Given this list of marker genes TRIP13, FCGR3A, ACTL6B, GMFG, NFE2L2, RAB15 (NCBI Gene Id 376267), NCF2, NRBP2, DLG3, GAS8, MED11, BCL2A1, HTRA1, NINJ1, PRICKLE1, PSD, TBC1D16, STX4, NIPAL3, TGFBR2, CD34, ASAH1, MYO1F (NCBI Gene Id 4542), FKBP1B, NEURL2, SNX5, TGFB3, C1orf54, BTG3, ARHGAP18, CFAP96 (cilia and flagella associated protein 96), C8G, ST6GALNAC4, EFEMP2, USP43, SLC39A12, BMPER, TUBA1A, PSAP, MTMR11, HTRA2, DENND1C (DENN domain containing 1C), VAT1, OAS1, GPR179, CYP2E1, SPHK1, TULP3, ZNF503, SYK, CCL2, AAK1, SPIN2A, SLC22A7, RHOH, LYL1, ARPC2, LAYN (NCBI Gene Id 143903), APOBEC3B, PLIN4, LAMA2, FOXP1, MMP3, GASK1B, EPB41L2, ANKRD33B, GNE, SNX27, IFIT2, SCNN1A, OTULINL, PTPRO, GSTM5, RGS19, CD200R1, KLKB1, EVA1A, MCM3, CAPN2, GATA6, SLC7A8, PLCD3, PRKCD, CTTNBP2NL, SLPI (secretory leukocyte peptidase inhibitor), GNB1, CD22, NOL4L, CDC42, C3AR1, SMOC2, HCST, TMEM229B, AGPAT4, C19orf38, RAB8B, TRPC4, IGSF8, CYGB, COMTD1, LRP12, PTGR2, DNA2, INIP, RGS18, PCDHB16, TRIL, GPNMB, TMEM273, KYAT1, CENPA, FABP7, CD180, LCE3B, SLC27A3, STK10, PLAUR (plasminogen activator, urokinase receptor), FES, PPM1L, CD86, SURF1, SLC41A2, SKP2, NPL, LRCOL1, SPTLC2, EMP3, SLFN12, WFS1, RCN1, PRAF2, SLC39A6, PDE3B (phosphodiesterase 3B), ANXA3, SDCBP2, HEATR1, CLN8, FBXO25, CNR2, ST8SIA4, CBFB, SRD5A3, LGR4, TONSL, AVPR1A, STAT4, ABCG1, HAVCR2, TRIM5, LTBP1, F2RL1, MYO9B, NUMBL, BIRC5, FHL1, IKBKE, SMIM5, MYO5A, APOBEC1, SYNGR1, CA2, TMEM164, PLXDC2, OLIG2, ARMC7, SNN, TMPRSS3, GALNT3, COMMD10, TEN1, MDFI, NLGN2, PIK3IP1, ELF3, HYCC1, CDKN2C, DCDC2C, TAX1BP3, LIPC, WFDC3, DOK2, TREM2, PMAIP1, PAWR, MRC1, SDC2, MYOF, PGM1, MANBA, SESTD1, UBD, PRKX, CHST14, KRT18, PTPRC, ITPR3, SLCO2A1, GDF10, TMEM43, AUTS2, MCL1, LRRC27, TTC39C, FEN1, SMS, RFTN2, SLAMF9, CAMKK1, GSS, CREG1, ADCY7, SERPINA11, EHD2, HILPDA, ESPL1, MAP3K8, ARPC1B, RUBCNL, SRGN, FRMD4A, RAP2B, TLR4, MYZAP, FKBP1A, MACIR, EHD4, HLA-DQA2, L1CAM, FSHR, MXRA8, CADPS2, CSF1R, TMEM144, BCL2L13 (NCBI Gene Id 25779), SDF2L1, RPIA, PLTP, PPIC, TREH, SYP, TUBB4A, AK8 (adenylate kinase 8), PTGER2, DDX31, MAP3K20, ATP6V1B2, CYRIB, OR4D6, ATP6V1A, SPACA9, CASP1, DDAH2, FUCA2, SLK, ME2, MELTF, LPL, RIPK3, TREX1, TIFAB, CDK15, RPS6KC1, FAM111A, PCGF3, GNS, GPATCH2, CYTIP, TANC1, PIMREG, B4GALT2, FAM83F, FGD6, OBSL1, LMNA, AFAP1L2, HOXB2, CASP2, HK2, PSRC1, SNX24, ZRANB3, LGMN (legumain), C3orf52, PKMYT1, PTK2B, TWF2, CDCP2, DCXR, PLA2G4A, GNMT, MRE11, MT3, CDK18, DRAM1, GSN, ACTG1, TPD52 (NCBI Gene Id 7163), CERS6, UNC93B1, LHFPL6, TNFAIP6, TFEC, SLC9A9, MAGIX, ATP13A2, CCDC120, GPR65, TGFB1I1, COL1A1, MAN2B1, ITM2C (integral membrane protein 2C), GPR137, PLA2G7, CADM1, NOSTRIN, CSF2RB, GALNS, GGT5, HPGDS, RAB34, CPNE9, DGCR2, PRMT2, ASGR1, TRAM1L1, CCL15, TOR4A, ZFYVE26, DOCK11, VIPAS39, DBH, LACC1, FRZB, LPXN, PBLD (NCBI Gene Id 64081), RNH1, HEPH, APH1B, PLXNB2, ARAP1 (ArfGAP with RhoGAP domain, ankyrin repeat and PH domain 1), OR56B4, NLRC4, RNF122, PCNA, ERMP1, MTHFD2L, NRG1, TPH2, SMPDL3A, ATP6AP2, APOL1, DNMT1, ZDHHC6, PALB2, CD84, PPIB, CD5L, PCOLCE, TXNRD1, SLC11A2, PIF1, PLEK, ICA1, EBI3, SAT1, POLD4, RBMS3, PRUNE1, KLHL6, INPP5D, FMN1, BIN3, P2RY10BP, IL11RA, DCK, ARHGAP25, NDRG2, HSD3B1, SEMA3G, NIBAN1, FBN1, C8B, ADCY6, GPSM3, MTHFD1, RNF217, FERMT3, NRP2, EML1, SLC43A1, PSMD8, SPRED2, C5, PIP5KL1, UCK2, ABCC5, CAPNS2, CPXM1, SPARC, SRXN1, MICAL2, UBTD1, ALDH1B1, IL33, MPEG1, P3H2, ANXA4, PLK2, OPN3, SLCO3A1, CD68, ZBTB48, PDLIM4, PIK3AP1, ANPEP, RASSF8, CTSH, UNC5B, PIP4P2, PDGFRB, CLEC10A, CCNA2, CAPG, PTPN1, TNIP1, TMSB4X, SYNPO (NCBI Gene Id 11346), LRIG1, KCNK13 (NCBI Gene Id 56659), TNC, IFI30 (IFI30 lysosomal thiol reductase), AK1 (NCBI Gene Id 203), ARL11, SLC4A7, TTC28 (tetratricopeptide repeat domain 28), GLIPR1, TAOK3, RAC2, ARHGAP10, HAL, ASL, SLAMF7, RHOJ, TCEAL5, RAB2A, CLIC1, SMOX, KCTD17, KCNN4, F10, SCN11A, FRAT1, AKR1B10, SNX1, RTL6, FAM131A, SCD, STXBP2, GJB1, CDS1, PRR13, DENND4B, PRR5L, SLC4A3, MFAP2, MSR1 (macrophage scavenger receptor 1), TYROBP, YWHAH, EPSTI1, TBC1D1 (TBC1 domain family member 1), PDGFRL, FLT3, TEC, TNFRSF18, MCMBP, PARP8, OASL2P, MSANTD3, CCDC102A, TAGLN2, HEXB, GADD45B, PRODH, STK24, PLXNC1, COL5A2 (NCBI Gene Id 1290), C1QB, HTRA3, ABCC4, IER5, MICU2, RPS6KA2, GLB1, PANX1, BACH1, TLE4, CLEC1B, PLXNB3, NECAB1, THEMIS2, OACYLP, TMEM86A, SCCPDH, UPB1, CYP4F2, SGPL1, FKBP10 (FKBP prolyl isomerase 10), C3orf80, PICALM, CLEC7A, NAIP, CD36, MAP3K15, UNC13D, IFIT3, BTC, RIN2, FBXO32, RIPPLY3, ANAPC13, HAUS8, PRODH2, ARRB2, CLDN22, FSCN1, P2RY14, CNDP2, OLFML3, ANTXR1, IL18BP, TNFAIP8, HACD4, ARHGDIB, VSIR, CACNB3, SLAMF6, MTRFR, OR51M1, IRF5, TBC1D9, CARD19, BST1, AIF1, PXMP2, GBA1, SCLY, NFAM1, ALDH3B1, VOPP1, CD63, FOS, F11 (NCBI Gene Id 72031), ENAH, CYP2C8, DROSHA, IL10RB (NCBI Gene Id 3588), TXNDC15, CIDEA, RAB11FIP5, FMOD, MAPK7, UBTD2, CARD11, ABCA5, TLR2, VIM, LDHB, GNB3, TOM1, DUSP10, TRIM32, SULF1 (NCBI Gene Id 23213), SERPINB9, LONRF3, CIDEC, SPMIP3, FOXS1, PRRX2, RGS14, SMC1B, ACY1, ZFP90, TK1 (NCBI Gene Id 7083), CD276, RIPOR3, AGMAT, PLEKHO1 (NCBI Gene Id 51177), STXBP5, ABR, OSTF1, SYBU, PYHIN1, GMNN, RAN, CHST12, COL14A1, MTHFS, STAB1, AKNA, CASP12, THBS2, DSE, EPB41, FRMD6, VAMP4 (vesicle associated membrane protein 4), LAT2, SPDL1, CYTH4 (cytohesin 4), FCGR2A, BICC1, DNAJB11, ACVRL1, IGSF6, PYCARD, CMAS, TPST1, ART4, GAL3ST1, LIPA, STEAP1, DOCK10, HK3, ADAMTS3, CDCA3, SERPINB6, RIPOR1, BLVRB, COLGALT1 (collagen beta(1-O)galactosyltransferase 1), SUSD4, GIPC2, CD44, CD14 (CD14 molecule), RNF207, CD38, B4GALT7, SORT1, NIBAN2 (niban apoptosis regulator 2), RGS10, JUN, AHCY, HMOX2, SLC31A1, COL16A1 (collagen type XVI alpha 1 chain), ARMC3, BLVRA, CFP, OBI1, GPX7 (NCBI Gene Id 91407), LAPTM5, RASSF5, PLGRKT, PEDS1, FCER1G, HMGA1, PPP1R14B, RHOV, SRPX, SH3BP2, EMILIN1, WSB2, CHTF18, PTCHD1, TNFSF13B, AIRN, DYSF, CSF3R, MPND, MZT2B, SAMSN1, ATP6V0A1, RASGEF1A, SLC5A4, MPV17L, ACE, MOCOS, ATAD2, SPATS2L, C1QC, SLC48A1, LOXL1, PILRA, CTC1, NLRC3, EAF1, LASP1, SLC6A6, PEA15, GPX8, LOXL2, IL1RL1, SPRR1A, WDR91, ATP1A3, DOCK2, CLCNKA, FBLN2, ATF3, ARPC5, HVCN1, SLC4A11, ACSS1, BGN, SYNGR2, VCAM1, RAB19, SH3BGRL3, SCPEP1, CERCAM, DNMT3A, FRRS1, CSTB, TSPAN33, CERS5 (NCBI Gene Id 91012), LGALS3BP, DPP7, CDC7, MMP13 (NCBI Gene Id 4322), SPATA6, KCTD10, PIP4K2A, KRTAP19-8, RASSF1, ECI2, COL1A2, BATF2, MSC, IGFBP2, PTPRE, LAIR1, HAGH, PTPN22, MMP2, SOAT1, CHSY1, NRROS, ALDH18A1, COTL1, PTPN13, FAR1, OIT3, CALHM2, GDPD1, MAN1C1, FAM83A, CBX6, NPDC1, PGS1, CYP4F8, PLEKHM2, TRUB2, NAP1L1, SLC11A1, ECSCR, ETFB, TNIP2, ITGAX, OSBPL8, ARID3A (NCBI Gene Id 1820), PFKP, ADPRH, SEMA3B, TMEM119 (NCBI Gene Id 338773), LXN, SLC2A10, CTSS, LILRA4, PCDHB18P, DOCK8, FETUB, ARL5C, FHL2, RPE65, GCH1 (GTP cyclohydrolase 1), ARHGAP4, DAPP1, FLNA, MFRP, CLEC4A, CFAP45, GATM, CCRL2, DUSP5, TRMT9B, EPB41L3, CALM3, IQGAP2, RFNG, GPM6B, PHF11, SLC6A8 (solute carrier family 6 member 8), ADGRE1, IRF8, PPM1J, PHYH, ENDOD1, ELOVL1, CD74, FMC1, GUSB (glucuronidase beta), MCUB, CYBB, HBS1L, TNF, HEY1, ADAM8, PLSCR1 (phospholipid scramblase 1), ARMC2, LGALS3, PPARG, FSTL4, S100A6, MMP27, P2RY6, ADAMTS2, CNMD, RASA4B, LTBP2, C11orf86, LCP1, ASF1B, AOPEP, S100A8, FAM216A, RHBDF1, CSF2RA, STRA6LP, TRAF5, P3H3, LTBP3, GPLD1, OLR1, ARHGAP45, ZNF521, SPTAN1, CD244, KIF22, SCIMP, ABI2, MCM5, DYNLL1, SS18L2, CCDC148, KLF1, CFL1, CXCL2, FZD5, BCS1L, SPIC (NCBI Gene Id 121599), IFNGR1, ADSS1, FN3K, SHTN1, EGR2, FMNL3, CTSK, GNG12, MYL12B, HCLS1, SNX20, MCOLN2, WAS, F7, AMZ1, TM4SF4, COL4A1, TMEM202, BMP8B, ANO6, CLCN5, RHOC, HPCAL1, TMEM132A, RAB3IL1, CALR, NAT8, UBA7, FUT7, ABL2, ANKFY1, FADS3, F13A1, CH25H, GAS2L1, TSPAN6, CD37, FLRT2, S1PR2, CLBA1, C6orf62, STAMBPL1, IL17RD, MAP4, ITGBL1, CCR5, TNFAIP2, SSTR2, AZIN1, LRSAM1 (NCBI Gene Id 90678), MYO1E, ENTPD1, CDH3, ANXA5, WDR1, GPAT3, ATP6V0D2, RDH12, SLC25A24, CHCHD6, SPRED1, JTB, PLAC8, REEP4, OXCT1, RGS2, NLRP10 (NLR family pyrin domain containing 10), GRN, LY86, RINL, PPM1H, CCN4, SRPX2, SIRPA, RASSF4, RNASE2, HEXA, ARHGAP9, RASA1 (NCBI Gene Id 5921), SEMA5A, HLA-DMB, ABHD12, HTR2B, TNIP3, CD3E, LYZ, TMEM165 (transmembrane protein 165), PLD4, BFAR, RALGDS (ral guanine nucleotide dissociation stimulator), DOK3, PMP22, KIF1C, IFNAR2, RAB31, CD83, SYNJ1, SLC7A6, B4GALT6, SUSD3, CORO1A, NANS, PADI2 (peptidyl arginine deiminase 2), RAB29, EBP, DUOXA1, VCAN, EXOC3L4, TMEM51, LMO2, GPR137B, GFRA4, NAGK, CDT1, CCL4, CBR3, P2RX4, PACSIN3, TUBB, CCL7, SYNGR4, ABCB4, ANKEF1, RASA3, FLAD1 (flavin adenine dinucleotide synthetase 1), S100A11, MFHAS1, BLNK, EPS8, TOR2A, HMCES, CAVIN1, TLR7, RASGEF1B, ATP6V0B, CHCHD7, TUBB2A, UBASH3B, SAMHD1, RNASEH2B, ADAP2 (ArfGAP with dual PH domains 2), ACP2, CKLF, POSTN, RENBP, SLC27A5, CMTM3, AJAP1, APBB1IP, ADAM19, TUBB6, PLEKHB2, EVI2A, BCL10, MYL12A, HOXD4, NLRP6, CTSB (cathepsin B), SLCO2B1, IRAG2, ALOX5AP, DNASE1L1, ARMCX2, MATN2, USP12 (ubiquitin specific peptidase 12), TPCN2, C19orf47, DIAPH3, CXCL14, SLC2A4, CD160, ZFAND2A, PLEKHA4, SLC15A3, BIRC7, OASL, FXYD5, PLEKHN1, RGS1, MTHFD2, SPI1, VAV1, POU3F1, ACER3, STX7, CD9 (NCBI Gene Id 928), TYRO3, PLB1, PLXDC1, ATP6V1C1, NCKAP1L, CES1, PLCG2, GPATCH3, MFGE8, CTSD, SESN1, SLC25A36, COLEC12, SLC35E4, GCNT1, ITGB2, RNF149, PLD3, FCGR1A, AP2M1, IL10RA, RAB7B, CD300A, LITAF, HIC1, SERPINA2, MAFB (NCBI Gene Id 9935), PLAT, CCDC3, NPC2, TRPV2, STXBP3, RELB, GSAP, LUM, CACHD1, PECR, AJUBA, AKR1A1, KLC4, RILPL2, TPM3, PHLDB1, MLANA, SLC35F6, DDT, TBPL1, FITM1, MOGAT1, FILIP1L, LDLRAP1, SDR42E1, TMEM52B, EVL, COL5A1, TEP1, MILR1, ARHGAP15, ANG, MS4A6A, STK17B, KRT8, PTGIR, SIGLEC5, STARD3, OR5P2, MMP23B (NCBI Gene Id 8510), SERPINA1, C16orf90, ARHGAP22, TM6SF1, CNRIP1, KCNN2, DUSP18, SLC25A10, ACTBL2, PRCP, BATF, PPL, LRRC52, COL6A1, ADGRE5, LPCAT2, PF4, CYP2D6, LOX, STXBP1, MYADM, WT1, RNF128, MS4A7, GDF3, DPYSL3, CYFIP1, ACOT9, LRRC25, NEDD9, GSTA2, IFI27, PKM, YIPF7, CLEC4D, COL6A3, PITPNM1, E2F8, ZNF385B (NCBI Gene Id 151126), SLC1A5, CCL23, PRKAG3, ENTPD2, FBLN5, CYSTM1, LILRB1, WASF1, KCNE3, SLC27A6, HOMER3 (homer scaffold protein 3), NIN, PTPN18, MEFV, S1PR5, ATP8B2, SPOUT1, SVEP1, BATF3, CYBA, ACTR3, FAM131B, NQO1, METRNL, PTPN6 (NCBI Gene Id 5777), SLC66A2, SMAP2, LCP2, LRRC39, ARPC4, OSBPL3, SLC37A2, PAM, CTPS1, VTN, SHANK1, ARHGDIA, PACC1 (proton activated chloride channel 1), IFNAR1, COL8A1, USP20, CCDC80, GLRX, MAGED2, DPEP2, SLC2A6, CD274, SPEG, CD48, ANXA2, VASN, SLC8A1, TRERF1, VAMP8, IGFALS, TMEM245, MMP12, GSDMD, FBLN7, MTFP1, SLAMF8, LAMP2, CD72, CA13, MMP19, RGL1, P2RY13, GMIP (NCBI Gene Id 51291), RCN3, ABI3, MSX2, MTPN, SP100, KNG1, NID1, CCL3, LYN (NCBI Gene Id 4067), CXCL16, LGI2, LACTB, NFKB2, SEMA4D, TMEM106A, SEMA6D (NCBI Gene Id 80031), WLS, ITPRID2, CRLF3, WDFY4, TCEAL1, SPSB2, SLC25A23, CYBC1, BEX3, ICOSLG, PI4K2A, PKIB, CD53, LGALS1, ITGAD, NCF4, CRAT, CLSPN, ITGAL, HAAO, here is a description of the gene set: Genes forming the macrophage-enriched metabolic network (MEMN) claimed to have a causal relationship with the metabolic syndrom traits. Human Gene Set: CHEN_METABOLIC_SYNDROM_NETWORK from publication Chen Y, Zhu J, Lum PY, Yang X, Pinto S, MacNeil DJ, Zhang C, Lamb J, Edwards S, Sieberts SK, Leonardson A, Castellini LW, Wang S, Champy MF, Zhang B, Emilsson V, Doss S, Ghazalpour A, Horvath S, Drake TA, Lusis AJ, Schadt EE (PMID 18344982) Identifying variations in DNA that increase susceptibility to disease is one of the primary aims of genetic studies using a forward genetics approach. However, identification of disease-susceptibility genes by means of such studies provides limited functional information on how genes lead to disease. In fact, in most cases there is an absence of functional information altogether, preventing a definitive identification of the susceptibility gene or genes. Here we develop an alternative to the classic forward genetics approach for dissecting complex disease traits where, instead of identifying susceptibility genes directly affected by variations in DNA, we identify gene networks that are perturbed by susceptibility loci and that in turn lead to disease. Application of this method to liver and adipose gene expression data generated from a segregating mouse population results in the identification of a macrophage-enriched network supported as having a causal relationship with disease traits associated with metabolic syndrome. Three genes in this network, lipoprotein lipase (Lpl), lactamase beta (Lactb) and protein phosphatase 1-like (Ppm1l), are validated as previously unknown obesity genes, strengthening the association between this network and metabolic disease traits. Our analysis provides direct experimental support that complex traits such as obesity are emergent properties of molecular networks that are modulated by complex genetic loci and environmental factors. studied in species Mus musculus